Given this list of marker genes ASS1, CPS1, KCNC2, SLC1A1, GRIA1, here is a description of the gene set: studied in species Homo sapiens Human Gene Set: GOBP_CELLULAR_RESPONSE_TO_AMMONIUM_ION Any process that results in a change in state or activity of a cell (in terms of movement, secretion, enzyme production, gene expression, etc.) as a result of an ammonium stimulus.